Given this list of marker genes EPHB1, MSTN, SIRT2, AKIRIN1, SIX4, here is a description of the gene set: Any process that stops, prevents or reduces the frequency, rate or extent of satellite cell differentiation. species: Homo sapiens Human Gene Set: GOBP_NEGATIVE_REGULATION_OF_SATELLITE_CELL_DIFFERENTIATION